Given this list of marker genes Etfbkmt, Acacb (acetyl-Coenzyme A carboxylase beta), Cnr1, Akt1, Plin5, Dbi (NCBI Gene Id 13167), Mfsd2a (MFSD2 lysolipid transporter A, lysophospholipid), here is a description of the gene set: studied in species Mus musculus Mouse Gene Set: GOBP_NEGATIVE_REGULATION_OF_FATTY_ACID_BETA_OXIDATION Any process that stops, prevents, or reduces the frequency, rate or extent of fatty acid beta-oxidation.